The following is a description of a gene set: species: Mus musculus Mouse Gene Set: chr2C2, and this is the list of marker genes: Gm13642, Metap1d, Klhl41, 4932414N04Rik (RIKEN cDNA 4932414N04 gene), Ubr3, Gm36002, Bbs5, Rpl9-ps7, Gm13633, Gm13739 (NCBI Gene Id 100416176), Hat1, Tlk1, Myo3b, Gm13623, Cfap210, Platr26, Gm13662, Gm13597, Gm13612, Dlx2, Gm36231, Phospho2 (phosphatase, orphan 2), G6pc2, Slc25a12, Lrp2, Fastkd1, Dync1i2, Ssb, Dhrs9, Cers6, Gm13641, Gm16510, Sp5, Nostrin, Mettl5os, Klhl23, Gorasp2, Dlx1 (distal-less homeobox 1), Mettl5, Gm13624, Gad1os, Spc25, Ppig, Abcb11, Mettl8, 4933409G03Rik (RIKEN cDNA 4933409G03 gene), Dlx1as, Erich2, Dcaf17, Gad1, Itga6, Cybrd1